The following is a description of a gene set: NR1H2 & NR1H3 regulate gene expression to control bile acid homeostasis studied in species Mus musculus Mouse Gene Set: REACTOME_NR1H2_NR1H3_REGULATE_GENE_EXPRESSION_TO_CONTROL_BILE_ACID_HOMEOSTASIS, and this is the list of marker genes: Ncoa1, Rxra, Ncor2, Nr1h2, Nr1h3, Rxrb